Given this list of marker genes SMAGP, NPDC1, GNAI1, CFD, DMXL2, AZU1, CRIM1, EEF1A2, SORBS3, SPRY1, CD34, MSRB1, ADGRL1, PPP1R16B, RNASE3, RNASE2, PXDN, PIK3C2B, FAM30A, MN1, PAWR, IGHM, RBPMS, F2RL1, SPTBN1, here is a description of the gene set: Genes that best predicted acute myeloid leukemia (AML) with the up-regulated expression of EVI1. from publication Valk PJ, Verhaak RG, Beijen MA, Erpelinck CA, Barjesteh van Waalwijk van Doorn-Khosrovani S, Boer JM, Beverloo HB, Moorhouse MJ, van der Spek PJ, Löwenberg B, Delwel R (PMID 15084694) Human Gene Set: VALK_AML_WITH_EVI1 BACKGROUND: In patients with acute myeloid leukemia (AML) a combination of methods must be used to classify the disease, make therapeutic decisions, and determine the prognosis. However, this combined approach provides correct therapeutic and prognostic information in only 50 percent of cases. METHODS: We determined the gene-expression profiles in samples of peripheral blood or bone marrow from 285 patients with AML using Affymetrix U133A GeneChips containing approximately 13,000 unique genes or expression-signature tags. Data analyses were carried out with Omniviz, significance analysis of microarrays, and prediction analysis of microarrays software. Statistical analyses were performed to determine the prognostic significance of cases of AML with specific molecular signatures. RESULTS: Unsupervised cluster analyses identified 16 groups of patients with AML on the basis of molecular signatures. We identified the genes that defined these clusters and determined the minimal numbers of genes needed to identify prognostically important clusters with a high degree of accuracy. The clustering was driven by the presence of chromosomal lesions (e.g., t(8;21), t(15;17), and inv(16)), particular genetic mutations (CEBPA), and abnormal oncogene expression (EVI1). We identified several novel clusters, some consisting of specimens with normal karyotypes. A unique cluster with a distinctive gene-expression signature included cases of AML with a poor treatment outcome. CONCLUSIONS: Gene-expression profiling allows a comprehensive classification of AML that includes previously identified genetically defined subgroups and a novel cluster with an adverse prognosis. studied in species Homo sapiens